The following is a description of a gene set: Human Gene Set: GOBP_GOLGI_TO_VACUOLE_TRANSPORT The directed movement of substances from the Golgi to the vacuole. studied in species Homo sapiens, and this is the list of marker genes: CCDC91, SORT1, AP1G1, AP4M1, ANKFY1, CLN3, VTI1B, LAPTM5, LAMP1, VTI1A, EHD3, AP3S1, VPS52, GAK, AP1G2, AP3D1, VPS54, RBSN, AP3S2